Given this list of marker genes GCKR, ANGPTL4, NR1H3, PLA2G12B, SIRT1, FITM2, APOA5, SCARB1, APOC2 (apolipoprotein C2), APOC1, GPIHBP1, LDAH, NR1H4, PNPLA8, APOC4, SESN2, ABCG8, ANGPTL3, OSBPL11, XBP1, MIR33A, PNPLA2, MIR208A (microRNA 208a), FUNDC2, SLC25A27, ABCG5, C1QTNF3, IL18, ACSM2A, OSBPL8, LPL, ADORA1, MLXIPL, ANGPTL8 (angiopoietin like 8), DGAT2, MTLN, MED13, APOA4, MIR379 (NCBI Gene Id 494328), APOA1, LIPC, MAP2K1, CETP, MIR34A, APOE, APOC3, RORA, HNF4A, here is a description of the gene set: species: Homo sapiens Any process involved in the maintenance of an internal steady state of acylglycerol within an organism or cell. Human Gene Set: GOBP_ACYLGLYCEROL_HOMEOSTASIS